Given this list of marker genes AZIN1, MED17, EHBP1, CLU, SLC20A1, TRIOBP, CD55, H1-0, SERPINH1, PPID, OSBPL1A, PIK3CB, MBD4, ARHGAP29, RIC8A, EZR, CST6, CTSB, XPOT, MALT1, CYB5A, IPO5, CAVIN1, WWTR1, LPGAT1, SLC3A2, SRP72, TIAM1, ATP6V1C1, GLRX2, TRIB3, PLOD2, SPCS1, CAPRIN1 (NCBI Gene Id 4076), GCN1, CYB5B, ERP29, PAPSS2, VCAN, RHOB, LPCAT4, CEPT1 (choline/ethanolamine phosphotransferase 1), PLIN3, ACYP1, SLC7A5, STK17A, UBE2S, AKAP12, SNX3, SPR, SH3GLB1, FGFR3, SMURF2, CEBPG, GNL3, SLC7A11, DHPS, LASP1, MSX1, YARS1, LPCAT1, APLP2, AGPS (alkylglycerone phosphate synthase), SMAD6, STK39, EIF4EBP1, AVEN, IDH3A, VEZF1, CYP24A1, CD47 (NCBI Gene Id 961), PTP4A2, MLEC, RGS2, SMS, CACYBP, SH3BP4, TOP1 (NCBI Gene Id 7150), IGFBP6, HSP90B1 (NCBI Gene Id 7184), TNFRSF6B (TNF receptor superfamily member 6b), MCUR1, SCD, QKI, CLIC4, PDIA6, MTHFD1, AHSA1, GNB1, HSPB1 (NCBI Gene Id 3315), ZNF217, GNPAT, SOX9, UGCG, DPYSL2, XRCC4, APBB2 (amyloid beta precursor protein binding family B member 2), ADD3, SSR1 (NCBI Gene Id 6745), MKNK2, ASNS, HPCAL1, MLPH, SLC39A14, PAPOLA, PSAT1, COX17, MARS1, GPRC5A, ACSL3, FHL1, TFRC, FKBP3, TAF1A, PDGFC, CEBPB, SLC35A1, FKBP4, LAMP2, ANXA3, P4HA2, SHMT2, LGALS1, here is a description of the gene set: from publication Tooker P, Yen WC, Ng SC, Negro-Vilar A, Hermann TW (PMID 17483357) Human Gene Set: TOOKER_GEMCITABINE_RESISTANCE_DN Acquired drug resistance is a major obstacle in cancer therapy. As for many other drugs, this is also the case for gemcitabine, a nucleoside analogue with activity against non-small cell lung cancer (NSCLC). Here, we evaluate the ability of bexarotene to modulate the acquisition and maintenance of gemcitabine resistance in Calu3 NSCLC models. In the prevention model, Calu3 cells treated repeatedly with gemcitabine alone gradually developed resistance. However, with inclusion of bexarotene, the cells remained chemosensitive. RNA analysis showed a strong increase of rrm1 (ribonucleotide reductase M1) expression in the resistant cells (Calu3-GemR), a gene known to be involved in gemcitabine resistance. In addition, the expression of genes surrounding the chromosomal location of rrm1 was increased, suggesting that resistance was due to gene amplification at the chr11 p15.5 locus. Analysis of genomic DNA confirmed that the rrm1 gene copy number was increased over 10-fold. Correspondingly, fluorescence in situ hybridization analysis of metaphase chromosomes showed an intrachromosomal amplification of the rrm1 locus. In the therapeutic model, bexarotene gradually resensitized Calu3-GemR cells to gemcitabine, reaching parental drug sensitivity after 10 treatment cycles. This was associated with a loss in rrm1 amplification. Corresponding with the in vitro data, xenograft tumors generated from the resistant cells did not respond to gemcitabine but were growth inhibited when bexarotene was added to the cytotoxic agent. The data indicate that bexarotene can resensitize gemcitabine-resistant tumor cells by reversing gene amplification. This suggests that bexarotene may have clinical utility in cancers where drug resistance by gene amplification is a major obstacle to successful therapy. Down-regulated genes in Calu3 cells (non-small cell lung cancer, NSCLC) resistant to gemcitabine which became up-regulated in response to bexarotene. species: Homo sapiens